Given this list of marker genes TRPV6, FGFR3, POMGNT1, NR2F1, WDR26, NOTCH3, here is a description of the gene set: studied in species Homo sapiens Short nasal bridge Decreased superior-inferior length of the nasal bridge, which is the saddle-shaped area that includes the nasal root and the lateral aspects of the nose. Human Gene Set: HP_SHORT_NASAL_BRIDGE